Given this list of marker genes DLD, BCKDK, PDK3, PDHA2, PDHB, TPK1, PDK1, PGK1, PDHA1, MPC2, PDK4 (pyruvate dehydrogenase kinase 4), PDHX, PDK2, DLAT, here is a description of the gene set: Human Gene Set: GOBP_PYRUVATE_DECARBOXYLATION_TO_ACETYL_COA species: Homo sapiens The chemical reactions and pathways resulting in the formation of acetyl-CoA from pyruvate.